Given this list of marker genes BDNF, PIK3CA, GDNF, MYO1H, KIF1B, EDN3, RET, PHOX2B, ASCL1, LBX1, here is a description of the gene set: Human Gene Set: HP_GANGLIONEUROMA studied in species Homo sapiens Ganglioneuroma A benign neoplasm that usually arises from the sympathetic trunk in the mediastinum, representing a tumor of the sympathetic nerve fibers arising from neural crest cells.